The following is a description of a gene set: studied in species Homo sapiens Human Gene Set: GOCC_PRESYNAPTIC_ENDOCYTIC_ZONE A specialized region of the plasma membrane and underlying cytoplasm which surround the the active zone, into which synaptic vesicle membranes are recycled following exocytosis. It is especially enriched in endocytic proteins following intense activity., and this is the list of marker genes: SNAP91, DNAJC6, CLTB, PICALM, PACSIN1, AP2M1 (NCBI Gene Id 1173), AP2B1, CLTA